The following is a description of a gene set: The chemical reactions and pathways involving one of a family of organic molecules consisting of a purine base covalently bonded to a sugar ribose (a ribonucleoside) or deoxyribose (a deoxyribonucleoside). Human Gene Set: GOBP_PURINE_NUCLEOSIDE_METABOLIC_PROCESS studied in species Homo sapiens, and this is the list of marker genes: APRT, GDA (guanine deaminase), PRTFDC1, PGM2, ADK, ADA, XDH, MTAP, GNMT, MACROD1, NT5C1A, ICMT, BLOC1S6, MAPDA, PTGDR, NT5C1B, ADA2, ACP3, HPRT1, NT5C2, NT5E, DGUOK, MACROD2, ENPP4, OARD1, NUDT1, PNP